Given this list of marker genes SIK1, SORL1, APOC3, SIRT1, MIR548P, GPLD1, CIDEC, FBXW7, APOC1, SREBF1, APOE, MIR30C1, APOBEC1, PIK3CG, MIR192, PLIN5, TMX1, here is a description of the gene set: Human Gene Set: GOBP_NEGATIVE_REGULATION_OF_TRIGLYCERIDE_METABOLIC_PROCESS studied in species Homo sapiens Any process that decreases the frequency, rate or extent of the chemical reactions and pathways involving triglyceride, any triester of glycerol.